Given this list of marker genes AURKC (aurora kinase C), AURKB, INCENP, NUMA1, KIF4A, BIRC5, RACGAP1, MAP10, KIF4B, PRC1, CDCA8, KIF23, here is a description of the gene set: species: Homo sapiens The cell cycle process in which the distance is lengthened between poles of the mitotic spindle. Mitotic spindle elongation begins during mitotic prophase and ends during mitotic anaphase B. Human Gene Set: GOBP_MITOTIC_SPINDLE_ELONGATION